The following is a description of a gene set: species: Homo sapiens Regulation of HMOX1 expression and activity Human Gene Set: REACTOME_REGULATION_OF_HMOX1_EXPRESSION_AND_ACTIVITY, and this is the list of marker genes: NFE2L2, HMOX1, BACH1 (BTB domain and CNC homolog 1), MAFK, HM13